The following is a description of a gene set: studied in species Mus musculus This event has been computationally inferred from an event that has been demonstrated in another species.<p>The inference is based on the homology mapping from PANTHER. Briefly, reactions for which all involved PhysicalEntities (in input, output and catalyst) have a mapped orthologue/paralogue (for complexes at least 75% of components must have a mapping) are inferred to the other species. Reactome Pathway: Metabolism of ingested MeSeO2H into MeSeH part of: Selenoamino acid metabolism electronically inferred by orthology from the curated human pathway, and this is the list of marker genes: Txnrd1